The following is a description of a gene set: studied in species Mus musculus from publication Schaeffer EM, Marchionni L, Huang Z, Simons B, Blackman A, Yu W, Parmigiani G, Berman DM (PMID 18794802) Early prostate development genes (up-regulated at 12 hr dihydrotestosterone) which are also up-regulated in high grade prostatic intraepithelial neoplasia (PIN) vs invasive cancer. Human Gene Set: SCHAEFFER_PROSTATE_DEVELOPMENT_AND_CANCER_BOX5_UP Cancer cells differentiate along specific lineages that largely determine their clinical and biologic behavior. Distinct cancer phenotypes from different cells and organs likely result from unique gene expression repertoires established in the embryo and maintained after malignant transformation. We used comprehensive gene expression analysis to examine this concept in the prostate, an organ with a tractable developmental program and a high propensity for cancer. We focused on gene expression in the murine prostate rudiment at three time points during the first 48 h of exposure to androgen, which initiates proliferation and invasion of prostate epithelial buds into surrounding urogenital sinus mesenchyme. Here, we show that androgen exposure regulates genes previously implicated in prostate carcinogenesis comprising pathways for the phosphatase and tensin homolog (PTEN), fibroblast growth factor (FGF)/mitogen-activated protein kinase (MAPK), and Wnt signaling along with cellular programs regulating such 'hallmarks' of cancer as angiogenesis, apoptosis, migration and proliferation. We found statistically significant evidence for novel androgen-induced gene regulation events that establish and/or maintain prostate cell fate. These include modulation of gene expression through microRNAs, expression of specific transcription factors, and regulation of their predicted targets. By querying public gene expression databases from other tissues, we found that rather than generally characterizing androgen exposure or epithelial budding, the early prostate development program more closely resembles the program for human prostate cancer. Most importantly, early androgen-regulated genes and functional themes associated with prostate development were highly enriched in contrasts between increasingly lethal forms of prostate cancer, confirming a 'reactivation' of embryonic pathways for proliferation and invasion in prostate cancer progression. Among the genes with the most significant links to the development and cancer, we highlight coordinate induction of the transcription factor Sox9 and suppression of the proapoptotic phospholipid-binding protein Annexin A1 that link early prostate development to early prostate carcinogenesis. These results credential early prostate development as a reliable and valid model system for the investigation of genes and pathways that drive prostate cancer., and this is the list of marker genes: ASPN, NREP, EMCN, PELI2 (pellino E3 ubiquitin protein ligase family member 2), PLPP3, PID1, SVIL (NCBI Gene Id 6840), EHBP1, SFRP1, ALDH1A1, ACER3